The following is a description of a gene set: Genes predicted to be targets of miRBase v22 microRNA hsa-miR-373-3p in miRDB v6.0 with MirTarget v4 prediction scores > 80 (high confidence targets). species: Homo sapiens Human Gene Set: MIR373_3P from publication Chen Y, Wang X (PMID 31504780), and this is the list of marker genes: MYRF, MBNL3, USP46, CNOT6, ABHD3, GNPDA2, RAB5C, BCL6, TFAP4, TBC1D2, ARMC8, MYCN, ST3GAL1, MYLK, RNF216, SPTLC2, RSF1, ISM2, AMER2, SPOP, PSD3, MCL1, NFIB, PAF1, HP1BP3, E2F5, ZNF385A, ARID4B, PRDM8, ZC3H13, RUBCN, TIAM1, RSBN1, FAT4, ADAM9, SPRED1, HECTD2, RELL1, APP, MAN1A1, ZKSCAN1, FGD5 (FYVE, RhoGEF and PH domain containing 5), ZNF362, CCNJ, FZD3, PPARA, HAUS8, AAK1, LAMA3, HDAC4, FGD4, CREB5, SON, GALNT3, JPT1, LEFTY2, ANKRD13C, ROCK2, DPP8, DNAJC27, CYP26B1, CYBRD1, ANKRD52, RFX3, RASSF2, PLAG1, RAB11A, MTF1, SLC33A1, DCAF6, EPHA5 (NCBI Gene Id 7304), WDR37, MAP3K2, GLIS3, SYDE1, SLAIN1, ZNF75A, TRAPPC14, MSL1, RUNX2, MKNK2, CMTR2, TNFAIP1, E2F2, PHKA1, PDE4D, HIPK3, RAB11FIP1, ITGB8, MED12L (NCBI Gene Id 57726), HIF1AN, UBE2B, REST, CXCL1, GPCPD1, SLAIN2, BTG1, HOOK3, ZBTB33, SMNDC1, YOD1, FSTL5, TAGAP, PTGDR, ALDH1L2, ARID5B, EXOC5, CLIP4, ZBTB11, SLC24A2, GPR6, ANO6, SNX8, SERF1A, CFL2, DCUN1D4, IKZF2, MFAP5, ZNRF3, LCOR, PLAGL2, BCAP29, DENND5B, ZNF827, BARX2, MIGA2, SLC40A1, ASF1B, PKHD1, ARHGEF10, SUV39H1 (SUV39H1 histone lysine methyltransferase), EZH1, LAMP5, PARP8, TAPT1, PHF14, KREMEN1, FZD6, RGMB, GLCE, PTPN21, SYNC, RAB11FIP5, DCUN1D1, UBE2Q2, MIER3, MAP3K14, LMO3, RTN1, TRIM36, RNF6, RELA, TBC1D8B, ZNF532, TSEN34, TMEM100, IRF2, GDF11, SNRK (SNF related kinase), LRP2 (LDL receptor related protein 2), RB1CC1, POLQ, KAT2B, MIXL1, ELK4, SKIDA1, ASF1A, ANKRD17, SAMD12, PFKP, PTPRD, TET2, ZNF367, SSX2IP, TANC1, PRDM4, LHX6, CCSAP, SLC15A2, PDIK1L, PKD2, KPNA2, USP24, TNKS2, TMEM170B, CYP20A1, LYST, MARCHF11, TCAIM, UBE2J1, NR4A3, SERF1B, MARCHF5, DUSP2, MTUS1, MCC, DPYSL5, JAZF1, C2CD2, ADAT2, ITPRIPL2, CPEB1, TIPARP, PDE8A, SLC22A23, LATS2, ARL4C, PIGM (NCBI Gene Id 93183), ZBTB41, RYR2, C6orf15, ASAP1, TRIP11, ARID4A, RRAGD, NUFIP2, SYTL4, OLFM3, TET3, FNDC3A, BLCAP, EIF3M, NHSL3, TMTC2, TMUB2, H2AJ, LEFTY1, ATAD2, TXNIP, PHF12, UNKL, NFYA, RGL1, FAM168B, SMARCC2, RAB22A, CORO2B, ST7L, RABGAP1, PAK2, MPC1, SUCO, CROT, ZNF800, MICA, ZFX, ARHGEF17, FRMD4A, TWF1, KIF3B, DRD1, E2F7, TMEM86A, KDM1B, REEP3, OXR1, QRSL1, PAK5, RBL1, ZBTB5, UNC80, CUX1, RASGEF1A, SDC1, PPP6C, NR2C2, HS2ST1, KMT5B, ZBTB7A, PRRG1, ATF6B, CAPRIN2, GUCA1C, CDCA7, R3HDM1, IRF2BP2, CYBB, SETBP1, NPAS3, TET1 (tet methylcytosine dioxygenase 1), ZRANB1, FYCO1, NFIA, GPM6A, ELAVL2 (NCBI Gene Id 1993), CYB5D2, CUX2, ARHGAP30, LRP8, CDC23, KIF26B, MBD2, CREBRF (CREB3 regulatory factor), C2orf69, TP53INP1, MAPK9, CELF2, ZFYVE26, TMEM123, GUCY1A1, TGFBR2, AGO1, COG5, DNAI7, TSHZ3, USP16, SRCIN1, TNRC18, RAD18, TMEM64, LHX8, DDHD1, INO80D, SS18L1, GPC6, VDR, VLDLR, BCL11A, DYNC1LI2, RPS6KA3, EDNRB